Given this list of marker genes ALDH18A1, TTC5, PEX16, ESAM, VPS41, EMC1, GBA2, HSD17B4, MDH2, CSF1R, FA2H, L2HGDH, AIMP1, IRF2BPL, OPA1, DNM1L, SLITRK2, NFU1, MAN2B1, STUB1, GFM2, POLR3K, ATP8A2, MAG, CACNA1E, NDUFA8, CPSF3, EIF2B4, BCAP31, here is a description of the gene set: Corpus callosum atrophy Human Gene Set: HP_CORPUS_CALLOSUM_ATROPHY studied in species Homo sapiens The presence of atrophy (wasting) of the corpus callosum.